The following is a description of a gene set: Mouse Gene Set: GOBP_URINARY_TRACT_SMOOTH_MUSCLE_CONTRACTION A process in which force is generated within smooth muscle tissue, resulting in a change in muscle geometry. This process occurs in the urinary tract. Force generation involves a chemo-mechanical energy conversion step that is carried out by the actin/myosin complex activity, which generates force through ATP hydrolysis. The urinary tract consists of organs of the body that produce and discharge urine. These include the kidneys, ureters, bladder, and urethra. studied in species Mus musculus, and this is the list of marker genes: Trpv1 (transient receptor potential cation channel, subfamily V, member 1), Kcnma1, Tbx3, Cacna1c, Tbx2, P2rx3, Atp2b4, Trpa1, Pla2g6, Tacr1, Htr2a, Ptger3, Tshz3, P2rx2, Htr7